The following is a description of a gene set: Human Gene Set: chr16p13 species: Homo sapiens, and this is the list of marker genes: SRRM2, ENSG00000263280, MLST8, CEROX1, TPSD1, MIR3180-1, ENSG00000291228, NPRL3, LMF1-AS1, PDPK1 (3-phosphoinositide dependent protein kinase 1), MIR3177, PKD1P3, RNU1-125P, ENSG00000261394, AXIN1, ENSG00000299216, RNA5SP404, NPIPP1, GLYR1, TPSB2, GRIN2A, C4orf46P1, LINC01177, MTATP6P24, OR1F1, ENSG00000199474, SNRPCP20, CLDN9, SRRM2-AS1, RPL23AP86, WASH4P, MTCYBP33, HS3ST6, MIR940, GNG13, UQCC4, CACNA1H, UBALD1, MAPK8IP3 (NCBI Gene Id 89855), AMDHD2, PKD1P1, CARHSP1, TVP23CP2, IFT140, MEIOB, ZNF75A (NCBI Gene Id 7627), CARHSP1-DT, SNORA64, SRL, GLIS2, ENSG00000262999, ENSG00000238685, ABCC6, ENSG00000293341, ZNF213-AS1, ALG1, BRICD5, RNU7-99P, SSTR5, MIR6511A1, MSRB1, RNU6-213P, SNORA78, PRSS41, ABCC1, NHERF2, IMPDH1P11, TXNDC11-AS1, RN7SL219P, CLDN6, LINC01290 (long intergenic non-protein coding RNA 1290), HBA2, MSLNL, NPW, MTCO3P24, MIR6767, LINC00921, RPL15P20, CLCN7, GFER, SMIM22, TEDC2-AS1, PDXDC1, ADCY9, CEP20, RN7SL743P, RSL1D1, DEXI, ENSG00000188897, MAPK8IP3-AS1, RN7SL274P, GREP1, PRSS21, MIR4717, RPS2, NUBP1, STUB1-DT, PLA2G10EP, FAHD1 (fumarylacetoacetate hydrolase domain containing 1), ENSG00000293232, CIAO3, PKD1, BFAR, RN7SL493P, HAGHL, PKD1P6, SNRNP25, GLIS2-AS1, PPL, RPS20P2, EME2, NDUFB10, MIR1225, HAPSTR1, ZSCAN10, CLEC16A (C-type lectin domain containing 16A), OR2C1, RPL21P119 (NCBI Gene Id 653737), ZG16B, TNFRSF17, NPIPA6, FLYWCH2, C1QTNF8, CPPED1, MIR3178, MIR548H2, MTND6P33, TSR3, MIR3677HG, NPIPA3, TNP2, ENSG00000262482, LINC02186, EIF1P4, DECR2, DDX11L10, ENSG00000263011, PRM3, ENSG00000295643, PKD1-AS1, C16orf89, TEDC2, CASP16P, ERCC4, SEC14L5 (NCBI Gene Id 9717), MPG, NAA60, C16orf96, C16orf90, SNORA10, ZNF263, MIR193BHG, NOMO3, CLUAP1, METTL22, UBL5P4, OR1F2P, NDE1 (nudE neurodevelopment protein 1), BMERB1, MIR3179-2 (NCBI Gene Id 100422886), GNPTG, CDIP1, DNAAF8, BAIAP3, RNPS1, JMJD8, MIR6768, PIGQ, LINC01195, GSPT1, SNHG19, SNORA3C, MMP25, ANTKMT (adenine nucleotide translocase lysine methyltransferase), NLRC3, PAM16, ENSG00000305760, MYH11, ECI1, ABCC6P2, NPIPB2, HBZP1, RHOT2, PDPK2P, CAPN15, PMM2, LINC02124, PRSS22, RPL7L1P19, LINC02164, E4F1 (NCBI Gene Id 1877), RRN3, TPSAB1, ZNF205, STUB1, SOX8, NUBP2, CASKIN1, METRN, LINC03107, MIR6770-1, MTND3P13, PKD1P6-NPIPP1, HBA1, FLYWCH1, TMEM186, NPM1P3, ABAT, MTCO1P28, PLA2G10FP, SEPTIN12, CCDC78, DNASE1L2, CCDC154, IGFALS (NCBI Gene Id 3483), SLX4, SHISA9, HBZ, ENPP7P14, TMEM114, VPS51P1, MIR6511B2, RPL35AP34 (NCBI Gene Id 100271641), TPSP2, USP7, RAB11FIP3, MIR3670-2, MIR3176, VASN, NTHL1, SNORD60, PLA2G10, CORO7, MGRN1, RGS11, ENSG00000260989, WDR90, PRM1, DDX11L16, MEFV, MIR6506, RN7SL850P, TMEM204, ENSG00000205890, RHBDF1, PLA2G10BP, ERVK13-1, MIR4516, TRAP1, LINC02130, WASIR2, LITAFD, PRSS27, RNU6-633P, CORO7-PAM16 (CORO7-PAM16 readthrough), ZC3H7A, NPIPA7 (nuclear pore complex interacting protein family member A7), MMP25-AS1, IL32, WDR24, BICDL2, MIR365A, LINC02185, ATP6V0C, PTX4, PARN, LINC00254, SOCS1 (NCBI Gene Id 8651), LMF1 (NCBI Gene Id 650392), MTND1P8, RSL1D1-DT, ENSG00000263279, TMF1P1, UBN1, ENSG00000260132, ZNF500, PKD1P2, NOMO1, TFAP4, MIR6511A2, RHBDL1, PDIA2, LINC01570, RPL7P46, ZSCAN32, MIR662, TPSG1, MTND5P33, LINC02861, RPUSD1, THOC6, NPIPA2, MIR3180-5, MRPS34, ATF7IP2, MIR8065, SNX29, NTAN1, RBFOX1, TXNDC11, PRR35, HNRNPCP4, DNASE1 (deoxyribonuclease 1), SNN, MIR5587, PRSS29P, NME3, SUB1P3, PRM2, MIR6126, UBE2I, PRSS33, COX6CP1, MIR6770-2, NTN3, IL9RP3, RNU6-457P, ARHGDIG, RPS26P52, CCNF, TSC2, MARF1, PERCC1, LINC02177, RNU7-125P, NPIPA5, RMI2, LITAF, NAGPA, NHLRC4, ZNF597, LINC02152, KREMEN2, RPS3AP2, ENSG00000260316, TNFRSF12A, SSTR5-AS1, CEMP1, HMOX2, MPV17L, HBQ1 (hemoglobin subunit theta 1), MIR1972-1, METTL26, MRPL28, MIR3677, ZNF213, RAB40C, TRAF7, RAB26, MIR6769A, MIR6511B1, RPS3AP48, HBAP1, NOXO1, PGP, ZNF174, POLR3K, RNA5SP403, PKMYT1 (NCBI Gene Id 9088), UNKL, ABCA3, ABCA17P, TIGD7, EEF2KMT, NMRAL1, HAGH, ZNF200, RNU1-22P, MIR4718, SYNGR3, LNCPTCTS, NPIPA1, TBL3, MIR6859-4, MRTFB, FBXL16, RNU7-63P, HCFC1R1, MIR193B, NME4, MSLN, FAM234A, PRSS30P, MIR3179-1, EMP2, DNAJA3, ZNF598, MTND4P34, MCRIP2, KCTD5, LINC00235, CHTF18, ELOB, ANKS3, ECI1-AS1, NUDT16L1, CREBBP (CREB binding protein), ENSG00000260378, RNF151, RPS23P6, RPL3L, RPL17P40, RNU6-328P, CIITA, BCAR4, TBC1D24, MIR3180-4, ROGDI, TELO2, ENSG00000300371, SNHG9, ENSG00000263080, PAQR4, LUC7L, PLA2G10GP, LINC01569, CRAMP1 (cramped chromatin regulator homolog 1), HBM, SPSB3 (NCBI Gene Id 90864), USP7-AS1, MIR3670-1, MIR3180-2, MIR6511A3, DPPA3P6, PGAP6, TEKT5, TVP23A, WFIKKN1, JPT2, MIR484, MTND4LP24